Given this list of marker genes Rspo1 (NCBI Gene Id 192199), Csnk1e (NCBI Gene Id 27373), Rnf213 (ring finger protein 213), Sfrp1, Rac1, Wnt7a, Fzd6, Wnt7b, Fzd5, Dab2, Ift80, Fzd7, Mir154 (NCBI Gene Id 387172), Wnt11, Dvl3, Spef1, Fzd4, Myoc, Vangl2, Rspo3, Znrf3, Tmem67, Lbx2, Fzd1, Tiam1, Csnk1d, Ankrd6, Wnt4, Nphp3, Abl2, Wnt9b, Dact1, Ccdc88c, Nkd1, Frzb, Fzd8, Wnt5b, Wnt3a, Lrp6, Ryk, Fzd2, Dvl1, Fzd10, Prickle1, Sfrp2, Plekha4, Fzd9 (NCBI Gene Id 14371), Fzd3, Dvl2, Gpc3, Ror2, Sfrp4, Mks1, Sfrp5, Abl1, Wnt5a, Cthrc1, Mllt3, Daam2, Med12, Celsr3 (cadherin, EGF LAG seven-pass G-type receptor 3), here is a description of the gene set: studied in species Mus musculus A type of Wnt signaling pathway in which Wnt binding to its receptor on the surface of a target cell results in the by propagation of the molecular signals via effectors other than beta-catenin. Mouse Gene Set: GOBP_NON_CANONICAL_WNT_SIGNALING_PATHWAY